The following is a description of a gene set: The presence of abnormal calcium deposition lesions in the pancreas. studied in species Homo sapiens Pancreatic calcification Human Gene Set: HP_PANCREATIC_CALCIFICATION, and this is the list of marker genes: CTRC (chymotrypsin C), TRPV6, ABCC6, CASR, ENPP1, PRSS2, SPINK1, PRSS1, CFTR (CF transmembrane conductance regulator), CPA1